Given this list of marker genes CEP55, SEPTIN9, NAA10, KIAA0586, OTUD5, SH3PXD2B, RTL1, ATP6V1E1, DLK1, WDR37, FIG4, ALDH18A1, ELN, FBLN5 (fibulin 5), PIGA, MEG3, FGFR2, MRPS16, TRAF7, TBX15, CSPP1, WDR81, PEX1, B4GALT1, CDK13, PRMT7, LZTR1, MRPS22, ATP6V1A, HRAS, NDUFB10, VAC14, ATP6V0A2, EBP, here is a description of the gene set: Redundant neck skin Human Gene Set: HP_REDUNDANT_NECK_SKIN species: Homo sapiens Excess skin around the neck, often lying in horizontal folds.